Given this list of marker genes AGL, TMIE, C1orf185, PHYH (phytanoyl-CoA 2-hydroxylase), KIF13A, GAA, ITGA7, GPATCH1, PTPN3, SH3BP5, STAT1, SLC5A3, NBN, FADS6, SPOUT1, AMZ2, MCCC2, CFAP410, DNAL1, C6orf118, UBE3A, ATP9B, AHI1, GNAO1, CCR4, CLRN3, CABLES1 (Cdk5 and Abl enzyme substrate 1), MRPL23 (mitochondrial ribosomal protein L23), PATJ, REEP2, CLHC1, DDX60, CALHM6, GARIN3, PRNP, DGKG, ZFP36L2, CORO6, SLAMF9, GADD45B, C2orf88, RAB39B, ZCCHC12, ARHGAP5, CAVIN2, KIF5C, OSGEP, TIGD2, ARID5B, NUDT6, ADAMTS3, LIAT1, TOM1L2, TBC1D4, IFFO2, NME7, ENDOD1, CARF, CYP4V2, AREL1, BAZ2A, LTA, NTRK3, NUDT16 (NCBI Gene Id 131870), RETN (NCBI Gene Id 56729), ATP1B1, GLRX5, PIBF1, FHL3, SNN, TCAIM, NFE2L2, BCOR, CEP290, CTSS, AKAP6, CARD14, KDM4D, CORO2B, ZNF808, ANP32A (NCBI Gene Id 8125), DNAJC13, PRDX2, EPRS1, PCCA, SERINC5, MRPS6, XPC, GRN, MYH3, REC8 (REC8 meiotic recombination protein), CCDC171, SSBP4, PGBD5, CBX6, CACYBP, NTPCR, TMEM158, FLCN, PAX5, ARHGAP18, GRIK4, USP53, TNFSF11, USP33, C3orf33, RPS26, CNKSR2, SDHAF2, ACADSB, AKAP11 (A-kinase anchoring protein 11), TMPRSS4, FRRS1, IFI44, PER1, MTAP, GDF5, HBP1, SLAMF6, ICA1L, PRXL2B, SOX30, PPP1R16B, PDK1, N4BP2L2, PFN2 (profilin 2), ZSCAN12, ENPP3, RTRAF, AFTPH, BTF3L4, SGPP2, ZNF346, PKP4 (plakophilin 4), ZNF365, DZIP1, DENND6B, CIPC, SLC6A6, SOD2, PIK3IP1, USP19, RCL1, TK2, SPRY3, SDF2, ABCG1, RGCC (regulator of cell cycle), SETD4, SNHG32, LIMS4, ZHX2, PHPT1, RSAD2, LAMP1, CD2AP, LIPA, KCTD7, CLIP2, TNFRSF12A, PECR, SH2B3, TCF7L2, ZNF583, EVA1C, MEIS3, PPTC7, INSR, STX4, SKP1, RPP40, PARM1, JAK2, TTLL12, SMO, ZER1, CCDC91, SLC22A12 (solute carrier family 22 member 12), RAMP3, OAS1, MON1B, UBR5, MTMR10 (NCBI Gene Id 54893), PAIP2, SPTLC1, TRIM44, RPS10, TSC1, GPIHBP1, GNA12, AR, CDK20, FARS2, CARM1, AP1S2, CCDC90B, BACE2, TICAM1, TNIP1, YDJC, here is a description of the gene set: Human Gene Set: GSE36078_UNTREATED_VS_AD5_T425A_HEXON_INF_MOUSE_LUNG_DC_UP Discrimination between self vs. non-self and adequate response to infection and tissue damage are fundamental functions of the immune system. The rapid and global spread of known and emerging viruses is a testament that the timely detection of viral pathogens that reproduce within host cells, presents a formidable challenge to the immune system. To gain access to a proper reproductive niche, many pathogens travel via the host vasculature and therefore become exposed to humoral factors of the innate immune system. Although a cascade of coagulation factors plays a fundamental role in host defense for “living fossils” such as horseshoe crabs (Xiphosurida spp), the role of the coagulation system in activation of innate responses to pathogens in higher organisms remains unclear. When human type C adenovirus (HAdv) enters the circulation, 240 copies of coagulation factor X (FX) bind to the virus particle with picomolar affinity. Here, using molecular dynamics flexible fitting (MDFF) and high resolution cryo-electron microscopy (cryo-EM), we defined the interface between the HAdv5 hexon protein and FX at pseudo-atomic level. Based on this structural data, we introduced a single amino acid substitution, T424A, in the hexon that completely abrogated FX interaction with the virus. In vivo genome-wide transcriptional profiling revealed that FX-binding-ablated virus failed to activate a distinct network of the early response genes, whose expression depends on transcription factor NFKB1. Deconvolution of the signaling network responsible for early gene activation showed that the FX-HAdv complex triggers MyD88/TRIF/TRAF6 signaling upon activation of toll-like receptor 4 (TLR4) that serves as a principal sensor of FX-virus complex in vivo. Our study implicates host factor “decoration” of the virus as a mechanism to trigger innate immune sensor that respond to a misplacement of coagulation FX from the blood into intracellular macrophage compartments upon virus entry into the cell. Our results further the mounting evidence of evolutionary conservation between the coagulation system and innate immunity. from publication Doronin K, Flatt JW, Di Paolo NC, Khare R, Kalyuzhniy O, Acchione M, Sumida JP, Ohto U, Shimizu T, Akashi-Takamura S, Miyake K, MacDonald JW, Bammler TK, Beyer RP, Farin FM, Stewart PL, Shayakhmetov DM (PMID 23019612) Genes up-regulated in Lung dendritic cell from untreated wildtype mice versus Lung dendritic cell from Ad5 T424A hexon infection wildtype mice. studied in species Homo sapiens